Given this list of marker genes C1QTNF9B, COL6A3, COL15A1, SCARA3, COL21A1, LOX, MBL2, COL4A2, COL6A2, COL8A1, COL6A5, COL11A1, COL16A1, FCN2, C1QC, COL4A4, COLQ, C1QL4, CCBE1, COL28A1, EMID1, C1QTNF2, FCN3, FCN1, C1QTNF5, COL18A1, COL25A1, COL5A3, COL6A6, COLEC10, C1QB, EMILIN2, COLEC12, C1QTNF1, EDA, EMILIN1, C1QA, COL17A1, SFTPD, C1QTNF9, C1QL3, GLDN, COL23A1, COL4A1, ADIPOQ, COL24A1, COL27A1, COL2A1, COLEC11, COL8A2, COL20A1, C1QTNF3, COL11A2, C1QL2, COL26A1, LUM, COL9A1, MARCO, C1QTNF8, COL1A2, COL4A3, SFTPA1, COL14A1, COL9A2, MSR1, SFTPA2, CTHRC1, OTOL1, COL10A1, COL6A1, COL12A1, C1QTNF7, WDR33, COL22A1, C1QL1, COL5A1, C1QTNF6, COL9A3, COL1A1, COL13A1, COL4A5, COL7A1 (NCBI Gene Id 1294), COL4A6, COL3A1, COL5A2, COL19A1, here is a description of the gene set: studied in species Homo sapiens A protein complex consisting of three collagen chains assembled into a left-handed triple helix. These trimers typically assemble into higher order structures. Human Gene Set: GOCC_COLLAGEN_TRIMER